Given this list of marker genes CYCS, GSDMD (NCBI Gene Id 79792), BAK1, GSDME, BAX, SEPTIN4, DIABLO, here is a description of the gene set: Release of apoptotic factors from the mitochondria Human Gene Set: REACTOME_RELEASE_OF_APOPTOTIC_FACTORS_FROM_THE_MITOCHONDRIA studied in species Homo sapiens